Given this list of marker genes Trmt112 (tRNA methyltransferase 11-2), Wdr4, Bud23, Mettl1, Ramac, Rnmt, here is a description of the gene set: Mouse Gene Set: GOBP_RNA_GUANINE_N7_METHYLATION species: Mus musculus The addition of a methyl group to the N7 atom in the base portion of a guanine nucleotide residue in an RNA molecule.